The following is a description of a gene set: The parkin was first identified as a gene implicated in autosomal recessive juvenile Parkinsonism. Deregulation of the parkin gene, however, has been observed in various human cancers, suggesting that the parkin gene may be important in tumorigenesis. To gain insight into the physiologic role of parkin, we generated parkin-/- mice lacking exon 3 of the parkin gene. We demonstrated here that parkin-/- mice had enhanced hepatocyte proliferation and developed macroscopic hepatic tumors with the characteristics of hepatocellular carcinoma. Microarray analyses revealed that parkin deficiency caused the alteration of gene expression profiles in the liver. Among them, endogenous follistatin is commonly upregulated in both nontumorous and tumorous liver tissues of parkin-deficient mice. Parkin deficiency resulted in suppression of caspase activation and rendered hepatocytes resistant to apoptosis in a follistatin-dependent manner. These results suggested that parkin deficiency caused enhanced hepatocyte proliferation and resistance to apoptosis, resulting in hepatic tumor development, partially through the upregulation of endogenous follistatin. The finding that parkin-deficient mice are susceptible to hepatocarcinogenesis provided the first evidence showing that parkin is indeed a tumor suppressor gene. from publication Fujiwara M, Marusawa H, Wang HQ, Iwai A, Ikeuchi K, Imai Y, Kataoka A, Nukina N, Takahashi R, Chiba T (PMID 18574468) Mouse Gene Set: FUJIWARA_PARK2_IN_LIVER_CANCER_UP species: Mus musculus Genes up-regulated in tumorous liver tissues from PARK2 knockout mice compared to the normal, non-tumorous tissue from wild type mice., and this is the list of marker genes: Afp, Il1rn, Golga3, Bax, Ccne1, Fst, Tnfrsf12a, Apoa4